Given this list of marker genes H2BC12, MBD4, H3-4, NTHL1, H2BC26, H2BC11, TINF2 (TERF1 interacting nuclear factor 2), H2BC13, H2BC4, H2AC20, NEIL1 (NCBI Gene Id 79661), H2BC3, H2AC14, H2BC12L, UNG, H2BC15, H2BC17, TERF2IP (TERF2 interacting protein), H2AC7, H4C1, H2AC4, H2BC14, H2AX, H2BC21, H2BC9, SMUG1, H2BC1, OGG1, TERF1, H2AJ, H2AZ2, NEIL3, H2AB1, TERF2, NEIL2, TDG, ACD, H2AC18, H2BC5, POT1, H2AC6, here is a description of the gene set: Reactome Pathway: Depyrimidination studied in species Homo sapiens part of: Base-Excision Repair, AP Site Formation Depyrimidination of a damaged nucleotide in DNA is mediated by a pyrimidine-specific DNA glycosylase. The glycosylase cleaves the N-C1' glycosidic bond between the damaged DNA base and the deoxyribose sugar generating a free base and an abasic i.e. apurinic/apyrimidinic (AP) site.